The following is a description of a gene set: Human Gene Set: DELPUECH_FOXO3_TARGETS_UP Genes up-regulated in DL23 cells (colon cancer) upon expression of an activated form of FOXO3. from publication Delpuech O, Griffiths B, East P, Essafi A, Lam EW, Burgering B, Downward J, Schulze A (PMID 17452451) species: Homo sapiens Forkhead transcription factors of the O class (FOXOs) are important targets of the phosphatidylinositol 3-kinase (PI3-kinase)/Akt pathway. FOXOs have been implicated in the regulation of cell cycle progression, oxidative stress resistance, and apoptosis. Using DNA microarrays, we analyzed the transcriptional response to FOXO3a activation by gene expression analysis in DLD-1 colon cancer cells stably expressing a FOXO3a.A3-ER fusion protein. We found that activation of FOXO3a resulted in repression of a number of previously identified Myc target genes. Furthermore, FOXO3a activation induced expression of several members of the Mad/Mxd family of transcriptional repressors, most notably Mxi1. The induction of Mxi1 by FOXO3a was specific to the Mxi1-SR alpha isoform and was mediated by three highly conserved FOXO binding sites within the first intron of the gene. Activation of FOXO3a in response to inhibition of Akt also resulted in activation of Mxi1-SR alpha expression. Silencing of Mxi1 by small interfering RNA (siRNA) reduced FOXO3a-mediated repression of a number of Myc target genes. We also observed that FOXO3a activation induced a switch in promoter occupancy from Myc to Mxi1 on the E-box containing promoter regions of two Myc target genes, APEX and FOXM1. siRNA-mediated transient silencing of Mxi1 or all Mad/Mxd proteins reduced exit from S phase in response to FOXO3a activation, and stable silencing of Mxi1 or Mad1 reduced the growth inhibitory effect of FOXO3a. We conclude that induction of Mad/Mxd proteins contributes to the inhibition of proliferation in response to FOXO3a activation. Our results provide evidence of direct regulation of Mxi1 by FOXO3a and imply an additional mechanism through which the PI3-kinase/Akt/FOXO pathway can modulate Myc function., and this is the list of marker genes: KIF3C, CAV1 (caveolin 1), GM2A, SLC31A2, TGFA, MXI1, HSPA1L, MAP3K5, AKR1C2, CLU, KIAA0040, SERPINB8, MXD1, CCN1, CD59, CDC42EP2, IGF1R, CDC14A, PIK3CA, KLF5, UBE2H, HPGD, GSN, EMP1, PHLDA2, WDR45, C11orf58, CORO1A, MVP (major vault protein), TIMP2, GTF2I, GNB5, CD9, DUSP6, IGFBP6, KLK10, BCL6, SPAG1, TNFRSF21, PIK3IP1, CD55, PLAUR, PLCG2, DUSP5, KRT6B, ABCC5, MARCKSL1, DAPK1, ERBB3, PDZK1IP1, MAX, SMPDL3A, RERE, TST, NEDD4L, SAT1, TNFAIP8, CCNG2, CLDN4, EDN1 (endothelin 1), LGR5, SEMA3C, CTSB, S100P, GRB7